Given this list of marker genes Etv4, A2m, Kif23, Clspn, Dpysl4, Rad51, Rab33a, Paqr8, Pdgfra, Prxl2b, Cenpn, Ncdn, Mthfd2, Lig1, Exo1, E2f7, Ednrb (endothelin receptor type B), Uhrf1, Mcm5, Pole, Cd24a, Nxph1, Tdrd7, Rrm2, Tle1, Rpgrip1 (retinitis pigmentosa GTPase regulator interacting protein 1), Gpm6a, Pdpn, Decr1, Efhd2, Trim2, Smc2, Cdc45, Bhlhe22, Ccnd2, Anln, Scg3, Cadm2, Atp9a, Cpq, Cldn11, Prkar1b, Pold1, Lsm12, Lrrfip1, Scn1b, Sgo2a, Trim62, D17H6S56E-5, Cit, Etv5, Omg, Gcat, Cdkn2a, Pllp, Nusap1, Myo1b, Nup107, Ppp2r2b, Fignl1, Pclaf, Rab29, Gpr137b, Mcm6, Spag5, Fzd6 (frizzled class receptor 6), Incenp, Clu, Gabrb1, Col4a6, Sdc4, Chrdl1, Bcas1, Uchl5, Crlf1, Tesc, Csdc2, Sparcl1, Vat1l, Nuf2, Thrsp, Racgap1, Cplx2, Cap1, F3, Aurka, Bmper, Ect2, Cd36, Dut (deoxyuridine triphosphatase), Plk4, Wnt7a, Jag1, Ccnd1, Mxra8, Ccn1, Rad54l, Cebpa, Cdt1, Hspb8, Cdc20 (cell division cycle 20), Golm1, Cdca3, Rtl8c, Chl1, Adgrg6, Zfp28 (NCBI Gene Id 76834), Rad51ap1, Socs2, Fen1, Kif18a, Psd, H4c6, Bex1, Gpd1, Ube2t, Car3, Rlbp1, Vwa1, Kif22, Nat8f1, Nasp (nuclear autoantigenic sperm protein (histone-binding)), Dbf4, Tubb3, Aurkb, Hells, Usp1 (NCBI Gene Id 230484), Syt4, Bmpr1b, Tmod1, Cited1, Rrm1, Rnd3, Shcbp1 (NCBI Gene Id 20419), Ass1, Lyn, Aldh1l1, Tmeff1, Csf2ra, Flot2, Ier3, Cd302, Nes, Pik3r3, Spp1, Pola1, Ecrg4, Otx2, Gnao1, Camk2d, Dusp6, Spry1, Ephb2, Aspm, Timp4 (NCBI Gene Id 21860), Ccnf, Acsl3, Lmnb1, Trib2, Aplp1, Cks2, Hopx, Ctnnal1, Vxn, Hfe, Spc25, Mapk1ip1l, Mt2, Rbl1, Cd38, Cks1b, Cnih2, Spry4, Ddx39a, Tuba4a, Unc5c, Mcm3, Birc5, Angpt1, Cenpq, Rnf128, Gpd2, Zfp367, Slc6a6, Ccnb1, Igfbp4, Dusp4, Rcc1 (NCBI Gene Id 66739), Tmeff2, Smoc1, Vwc2, Robo2, Mis18bp1, Il13ra1, Hip1, Cpped1, Slc6a11, Serpinb6a, Cp, Reep3, Mmp15, Tk1, Spsb4 (NCBI Gene Id 331009), Top2a, Mcm2, Ptprd, Sh3bp4, Ndc80, Rassf3, Ctnnbip1, St6gal2, Upp1, Asph, Prc1, Ctps1, Sema3a, Pla2g7, Fbn2, Rbp1, Plk1, Nrcam (neuronal cell adhesion molecule), 2310022B05Rik (RIKEN cDNA 2310022B05 gene), Mad2l1, Ctsl (NCBI Gene Id 320361), Cdca8, Kif4, Tpx2, Ugt8a, Jmjd8, Fbln2, Fbxo32, Sdk2, Nupr1, Plpp3, Mfge8, Pfkp, Metrn, Melk, Mbp, Bub1, Mcm4, Cpne8, Lhfpl2, Tagln3, Snx18, Als2cl, Acot7, Rfc4 (replication factor C (activator 1) 4), C4b, Ccnb2, here is a description of the gene set: The glioblastoma multiforme (GBM) plasticity signature: genes up-regulated in neural stem cells (NSC) with double knockout of TP53 and PTEN vs those with knockout of TP53 alone. Glioblastoma (GBM) is a highly lethal brain tumour presenting as one of two subtypes with distinct clinical histories and molecular profiles. The primary GBM subtype presents acutely as a high-grade disease that typically harbours mutations in EGFR, PTEN and INK4A/ARF (also known as CDKN2A), and the secondary GBM subtype evolves from the slow progression of a low-grade disease that classically possesses PDGF and TP53 events. Here we show that concomitant central nervous system (CNS)-specific deletion of p53 and Pten in the mouse CNS generates a penetrant acute-onset high-grade malignant glioma phenotype with notable clinical, pathological and molecular resemblance to primary GBM in humans. This genetic observation prompted TP53 and PTEN mutational analysis in human primary GBM, demonstrating unexpectedly frequent inactivating mutations of TP53 as well as the expected PTEN mutations. Integrated transcriptomic profiling, in silico promoter analysis and functional studies of murine neural stem cells (NSCs) established that dual, but not singular, inactivation of p53 and Pten promotes an undifferentiated state with high renewal potential and drives increased Myc protein levels and its associated signature. Functional studies validated increased Myc activity as a potent contributor to the impaired differentiation and enhanced renewal of NSCs doubly null for p53 and Pten (p53(-/-) Pten(-/-)) as well as tumour neurospheres (TNSs) derived from this model. Myc also serves to maintain robust tumorigenic potential of p53(-/-) Pten(-/-) TNSs. These murine modelling studies, together with confirmatory transcriptomic/promoter studies in human primary GBM, validate a pathogenetic role of a common tumour suppressor mutation profile in human primary GBM and establish Myc as an important target for cooperative actions of p53 and Pten in the regulation of normal and malignant stem/progenitor cell differentiation, self-renewal and tumorigenic potential. species: Mus musculus Mouse Gene Set: ZHENG_GLIOBLASTOMA_PLASTICITY_UP from publication Zheng H, Ying H, Yan H, Kimmelman AC, Hiller DJ, Chen AJ, Perry SR, Tonon G, Chu GC, Ding Z, Stommel JM, Dunn KL, Wiedemeyer R, You MJ, Brennan C, Wang YA, Ligon KL, Wong WH, Chin L, DePinho RA (PMID 18948956)